The following is a description of a gene set: Mouse Gene Set: GOBP_REGULATION_OF_ACTIN_FILAMENT_BUNDLE_ASSEMBLY species: Mus musculus Any process that modulates the frequency, rate or extent of the assembly of actin filament bundles., and this is the list of marker genes: Arhgef10 (NCBI Gene Id 234094), Was, Kank2, Alms1, S1pr1, Rock2, Ppm1e, Stmn1, Pak2, Braf, Rapgef3, Pdlim4, Mkks, Myoc, Pik3r1, Plek, Pik3r2, Bag4, Prkcq, Pfn3, Rac1, Arhgef15, Mtss1, Lpar1, Ppp1r9a, Wnt11, Cfl1, Arhgap6, Evl, Abl1, Tsc1, Sorbs3, Gpr65 (NCBI Gene Id 14744), Carmil1, Apoa1, F11r, Coro2b, Rhoa, Nf2, Smad3, Asap3, Sh3pxd2b, Synpo, Nrp1, Tmeff2, Wnt4, Synpo2, Ccn2, Ccdc88a, Pak1, Arhgef5 (NCBI Gene Id 72382), Met, Tgfbr1, Arap1, Pfn2, Pfn1, Flna, Dlc1, Kank3, Tmsb15b2 (thymosin beta 15b2), Ppm1f, Tmsb15l, Arhgef18 (Rho/Rac guanine nucleotide exchange factor 18), Cd47, Map3k1, Ppfia1, Kiss1r, Tacstd2, Dbn1, Pxn, Tpm1, Limch1, Limk1, Bbs4, Epha1, Actg1, Synpo2l, Rhpn1, Mtor, Serpinf2, Nox4, Rgcc, Prkn, Frmd7, Clasp2, Rdx, Ttc8, Cgnl1, Sdc4, Ptger4, Fhod1, Swap70, Tacr1, Fermt2, Tgfb3, Inpp5k, Tjp1, Arhgap28, Pfn5, Tac1, Vil1, Phldb2, Shank3, Rhoc, Cx3cl1, S100a10, Id1, Arhgef10l, Cdc42, Wasf2, Shank1, Itgb1bp1, Rhpn2, Kank4, Tesk1, Clasp1